Given this list of marker genes ZMYM5, ERLIN1, NOL10, NKX2-3, DLK1, SERTAD1, CRLF1, DIAPH1, CAPN6, BCL11A, ZNF362, STX12, OTP (NCBI Gene Id 23440), ARIH1, RAPGEFL1, LMTK2, SGIP1, DCAF1, JAG1, ADIPOR2, NAB2, S100A10, EMP3, SSBP3 (NCBI Gene Id 55126), PPP1R11, LIN28A, EEF1A1, here is a description of the gene set: Human Gene Set: TAXCREB_02 studied in species Homo sapiens Genes having at least one occurrence of the motif RTGACGCATAYCCCC in the regions spanning 4 kb centered on their transcription starting sites. This matches the transcription factor binding site V$TAXCREB_02 (v7.4 TRANSFAC).